Given this list of marker genes BEST3, NGDN, NIPA1, RYR2, YBX1, GSG1L (NCBI Gene Id 146395, GSG1 like), FOXR2, AR, STOX2, PCDH12, STK25, C20orf173, IREB2, MROH8, YWHAZ, IGLL5, GMCL1, CCDC50, KRT10-AS1, SWT1, SEC23IP, CTNND2, ZNF449, NF1, AK2, ENTPD5, PIAS2, KLK10, FAM135A, PCBP2, METTL4, ZNF425, UCP2, KLF12, SLC18A2, UBE2Z (ubiquitin conjugating enzyme E2 Z), IL1R1, ADAMTSL1, RANBP3L, ADCY9, FAM169BP, PDE8B, PALMD, OPRM1, MORF4L1, PANK3, NAT1, ZWINT, here is a description of the gene set: from publication Chen Y, Wang X (PMID 31504780) Genes predicted to be targets of miRBase v22 microRNA hsa-miR-6744-5p in miRDB v6.0 with MirTarget v4 prediction scores > 80 (high confidence targets). studied in species Homo sapiens Human Gene Set: MIR6744_5P